Given this list of marker genes NDUFV2, NDUFV3, MT-ND2, NDUFB2, NDUFA4, NDUFA5, NDUFB8, NDUFS7, NDUFA1, MT-ND4L, NDUFS1, NDUFA7, MT-ND1, NDUFB7, NDUFC1, AIFM1, NDUFC2, NDUFB6, NDUFV1, NDUFB3, MT-ND5, MT-ND4, MT-ND3, NDUFB4, NDUFB9, NDUFS4, NDUFA6, NDUFA3, NQO1, NDUFS2, NDUFS3, NDUFB1, NDUFA12, NDUFA2 (NCBI Gene Id 4695), NDUFA8, NDUFS5, NDUFS8, MT-ND6, ENOX1, NDUFS6, NDUFB5, NDUFA10, NDUFA9, NDUFB10, here is a description of the gene set: studied in species Homo sapiens Catalysis of the reaction: NADH + H+ + acceptor = NAD+ + reduced acceptor. Human Gene Set: GOMF_NADH_DEHYDROGENASE_ACTIVITY